The following is a description of a gene set: Human Gene Set: MODULE_533 species: Homo sapiens Genes in the cancer module 533., and this is the list of marker genes: TRIM22, KRT19, VAMP2, CDC20, KRT13, ZWINT, MYH11, SEPTIN5 (septin 5), NCAM1, MAPT, CCNT1, CORO1A, TUBB4A, AMPH, FAM107A, LAMC2, NELL1, SNAP25, KIF5C, RAPH1, CENPF, USP37, LZTS3, ARHGAP4, AOC3, TUBA4A, STX1A, CYTH1, DTNB, STMN2, THBD, MYH7, LAMB1, NEFL, KRT17, BIVM, MID1, AGAP3, DYNC1I1, TACC2, KRT6B, STMN1, LMNB1, SEPTIN4, KIF5A